Given this list of marker genes Ctsg, Itgam, Pram1, Cd177, Pomc, Ace, Myd88, Syk, Dnase1l3, Lypd10, F2rl1, Cd300lb, Arg1, Itgb2l, Irak4, Tusc2, Abr, Scnn1b, Dnase1, Trem1, Cxcl1, Kmt2e, Jagn1 (NCBI Gene Id 67767), Anxa3, Elane, Nlrp6, Stxbp3, Cxcl5, Wdr1, F2, Dao, Lyst, Bcr, Spi1 (Spi-1 proto-oncogene), Myo1f, Ncf1, Itgb2, Lypd11, Stx11, Card9, Ptafr, Pikfyve, Pcyox1l, Trem3, here is a description of the gene set: species: Mus musculus Mouse Gene Set: GOBP_NEUTROPHIL_MEDIATED_IMMUNITY Any process involved in the carrying out of an immune response by a neutrophil.